The following is a description of a gene set: Human Gene Set: HP_VISCERAL_ANGIOMATOSIS studied in species Homo sapiens Visceral angiomatosis, and this is the list of marker genes: FGFR1, SMAD4, GNAQ, IDH2, SLC26A2, FGFR2, AKT1, GDF2 (NCBI Gene Id 51423), ENG, TEK, IDH1, ACVRL1, PTEN, PIK3CA, PTH1R, KRAS